Given this list of marker genes APOA5, MTTP, NGLY1, APOB, ALG6, APOC3, SAR1B, MSMO1, B4GALT1, FDFT1, ANGPTL3, LDLRAP1, GPIHBP1, here is a description of the gene set: An decreased concentration of low-density lipoprotein cholesterol in the blood. Human Gene Set: HP_DECREASED_LDL_CHOLESTEROL_CONCENTRATION studied in species Homo sapiens Decreased LDL cholesterol concentration